The following is a description of a gene set: Human Gene Set: GOBP_PHENYLPROPANOID_METABOLIC_PROCESS The chemical reactions and pathways involving aromatic derivatives of trans-cinnamic acid. studied in species Homo sapiens, and this is the list of marker genes: CYP2D6, UGT1A8, CYP2A7, UGT1A7, CYP2A13, CYP1A1, CYP2A6